Given this list of marker genes IGKV2D-28 (NCBI Gene Id 28883), KIF26B, RIN1, TOR1B (NCBI Gene Id 84822), TOR1A, DNASE2, VPS36, UBB, IGLV2-11, AP4B1, DNM2, KLC1, KIF15, COPS6, STAM, NAA35, KIF20A, TRAPPC13, EPGN, SURF4, GNS, PAFAH1B2, COL3A1, COG7, GOLGA1, TBC1D4, BICD2, HPS1, COPB2, ANKRD28, CALM1, IGLV1-40 (NCBI Gene Id 28825), SYS1, GJB7, RAB13, DENND6B, HSPA8, VAMP2, SNAP91, NAPG, STXBP3, TBC1D7, IGKV3-15, MASP1 (MBL associated serine protease 1), CYTH4, STX5 (NCBI Gene Id 6811), MON1B, SCFD1, EPS15L1 (NCBI Gene Id 58513), MON1A, GRB2, TPD52L1, HGS, BLOC1S4, RHOBTB3, SPTBN1, KIF12, DVL2, TBC1D1, TGOLN2, DAB2, PLA2G4A, TRAPPC10, RAB11A, ARPC3, IGHV3-53 (NCBI Gene Id 28420), TUBA4A, CD55, PPP6R1, DYNC1LI1, IGLV1-51, IGLV7-43, IGLV6-57, VPS37A, IGHV3-13, CAPZA1, ARPC2, MCFD2, KIF1C, IGKV1D-12, IGLC3, BIN1, APOA1, HSPH1, RHOQ, CTTN, MAN1C1, GJA1, TMED9 (NCBI Gene Id 96645), TPD52, IGKV3-11, ACTB, AKT2, SNF8, CHMP6, TRAPPC8, TRAPPC2L, RABEP1, KIF22, TUBA1A, AP1S1, VPS45 (NCBI Gene Id 11312), TUBB8B, WASL, SEC24C, ARF3, RAB3IL1, ITSN2, NAPA, SPTB, RAB41, RACGAP1, SNX18, DENND2B, IGLV3-27, SH3D19, NAA38, IGHV3-7, TUBB8, KIF2B, BET1, RGP1, GJA4, GOSR1, KIF5A, RAB27B, YWHAB, EGF, ARFRP1, HSP90B1, RAB5C, TMED3, KIF2A (kinesin family member 2A), MAN2A2, F8, TRIP11, DCTN5, KIF25, SEC16B, NEDD8, PIP5K1C, COPS3 (COP9 signalosome subunit 3), YIPF6, MAN1A2, KIF5B, GRIA1, RAB1A, BTC, IGKV2-30, IGLV1-47, ARCN1, RAB33A, RAB33B, SLC18A3, STAM2, RALA, WNT5A (Wnt family member 5A), PLIN3, PRKAB2, AP1S3, RAB3IP, AP4S1, IGLV3-25, RAB18, SCGB3A2, ARFGAP2, MADD, UBQLN2, IGHV4-39, KIF3C, GAPVD1, DENND3, CCZ1 (NCBI Gene Id 51622), TRAPPC4, ARF6, VPS37D, IGKV2D-30, MYO5A, YKT6, COPB1, LRP1, BICD1, COPS7A, DNAJC6, STX17, CAPZA2, DENND2D, LDLRAP1, AP2S1, ARFGAP1, SEC31A, VAMP4, SSC5D, ARF5, NAPB, TUBA3C, AP4M1, PRKAG1, RAB9B, IGHA1, PIK3C2A, EXOC5, RALGAPB, PAFAH1B1, GDI1, SEC13, AP3B1, CSNK1D, AP2A1, GOLGA5, SNAPIN, SAA1, DCTN6, CD3G, SNAP29, CYTH3, SLC2A8, COG1 (NCBI Gene Id 9382), GCC1, ANK1, CHMP2A, REPS2, AP1G2, AP3S1, ACTG1, TBC1D25, TUBB6, ARRB2, IGHV4-59, HBEGF, IGLC2, IGHV1-69 (NCBI Gene Id 652126), EXOC8, KIF18B, GRK3 (NCBI Gene Id 157), PAFAH1B3, GABARAPL2, RAB1B, SH3GL3, ACTR10, EXOC4, SEC23IP, F5, DTNBP1, GOSR2, TMED2, SBF1, COG2, PRKAB1, CPD, VPS4A, GGA2, APOB, KIF19, IGKV5-2, CLTB, AP2B1, RAB35, EXOC3, BLOC1S3, ALPP, COPZ2, TRAPPC11, RAB38, GJB6, HIP1, EXOC6, CYTH2, IGKV2D-40, C2CD5, SH3GL1, RIN3, UBA52, GOLGA2, LMAN1L, DENND1B, GORASP1, COPA, FCHO1, RAB43, ARF4, COPS7B, VTA1, SNAP23, IGHV3-33, ANKRD27, DENND1C, IGHA2, CTSC, MAN2A1, GJD4, TJP1, ACTR2, DYNLL2, RAB8B, PACSIN2, SYT1, REPS1, CAPZB, HSP90AA1, BNIP1, SPTBN4, UBC, HYOU1, ACTR1A, TBC1D13, GPS1, TRAPPC2, TBC1D15, RAB9A, COPS2, SGIP1 (NCBI Gene Id 84251), VPS37B, IGKV1-5, CNIH3, ARRB1, CHMP7, TBC1D3, AKT3 (NCBI Gene Id 26068), VAMP7, FOLR1, ULK1, IGKV3-20, COL7A1, RAB12, CAPZA3, STX10 (syntaxin 10), SCARB2, CD59, VPS54, TUBA4B, DENND6A, CD4, COPS5, KIF21B, GJC1, SCARA5, GBF1, TF, RAB27A, TUBB2A, GJD3, IGKV1-12, IGKV1-33 (NCBI Gene Id 28933), NSF, TXNDC5, SH3KBP1, COPZ1, TRAPPC12, IGLV2-14, CFTR, VPS53, MIA3, YWHAH, SEC23A, TBC1D14 (TBC1 domain family member 14), MARCO, GCC2, TACR1, DYNC1I1 (NCBI Gene Id 1780), ACTR3, CCZ1B, STX6, EPN1, CLVS1, AVP, COPS4, AP1B1, KLC2, CD36, CUX1, ARFGAP3, GJA10, TRAPPC3, SH3GL2, LNPEP, MAN1A1 (mannosidase alpha class 1A member 1), CLTC, IGKV1D-33, RABGAP1, CHMP4A, KIF23, TFG (NCBI Gene Id 50989), SYT8, EPS15, IGLV3-1, IGLV1-44, PACSIN3, DNM1, TBC1D17, GOLGA4, RIN2 (Ras and Rab interactor 2), ANK2, IL7R, SFN, GOLIM4, RAB21, CHMP2B, IGKV1-39, HBA1, IGHV3-23, GALNT2, STON1, SPTBN2, ARPC1A, TRIP10, IGF2R, INS, IGHV2-70, VAMP8, AGTR1, TBC1D2, CLINT1, HIP1R (huntingtin interacting protein 1 related), SNX5, RAB14, PUM1, CHMP3, MAP1LC3B, AVPR2, CNIH1, TUBA3E, NECAP1, IGHV3-11 (NCBI Gene Id 28450), RAB10, IGLV2-23, RAB3A, SRC, KIF1A, DYNC1H1, AP1M1, AGPAT3, MYH9, COG6, ALS2, TGFA, GDI2, AP4E1, AP1S2, HPR, SPTAN1, FNBP1, SEC31B, GGA3, SYT2, RAB31, YWHAE, DCTN1, NECAP2, RAB11B, KIF26A, APP, CLTA, VPS52, IGHV4-34, SLC2A4, COL4A1, PREB, KIF3B, AMPH, IGKV1-16, RPS27A, ADRB2, TBC1D10A, DNM3, KIF4B, KIFC1, STX18, IGKV1D-39, ANK3, HPS4, SEC24B, KIF6, YWHAQ, DENND4A, RALGAPA2, OPTN, RAB6B, LMAN2L, GJB5, COPS8, RAB7A, TFRC, GJA5, IGHV1-46, SNX2, GJB1, SNX9, ARFIP2, FCHO2, RAB4A, CD163, UBQLN1, PRKAG2, MYO1C, IGHV3-30, SYT9, ZW10, GJA3, TUBB2B, BLOC1S1, TMED7, AREG, GJB4, SEC24A, SYNJ1, GJA8, BET1L, PPP6R3, USE1, SEC22C, VPS25 (vacuolar protein sorting 25 homolog), KLC4, COG5, EGFR (epidermal growth factor receptor), MVB12A, GGA1, DYNLL1 (NCBI Gene Id 8655), FNBP1L, KIAA0319, TSC2, CENPE, TUBB4A, BLOC1S6, DYNC1LI2, IGLV3-19, CD3D (NCBI Gene Id 915), RINT1, IGKV4-1, CHMP4C, JCHAIN, DENND5A, CLTCL1, GJA9 (gap junction protein alpha 9), KIFC2 (NCBI Gene Id 90990), RAB32 (NCBI Gene Id 10981), DENND2C, ITSN1, COPE (COPI coat complex subunit epsilon), TUBB1, SBF2, EPN2, ASPSCR1, TUBAL3, TBC1D20, IGHV3-48, DENND4C, LMAN1, STON2, MYO6, COPG2, IGLV3-21, CHRM2, RIC1, RAB3GAP1, IGLV2-8, TRAPPC6A, CHMP4B, COG4, EXOC2, SERPINA1, TSG101, CLVS2, ARPC5, SPARC, DENND5B, M6PR, KDELR1, HPX, NBAS, PRKAG3, KDELR3, KIF27, KIF20B, TBC1D8B, PLA2G6, COLEC12, GALNT1, UBAP1, RAB7B, EXOC7, LRP2, AAK1, STAB2, AP1G1, TBC1D16, GABARAP, AP1M2, COPG1, SEC22A, KIF3A, TRAPPC6B, AKT1, EREG, LDLR, COG3, SCARF1, TRAPPC1, DCTN4, RINL, GAK, TMEM115, RAB39A, DYNC1I2, RAB39B, COG8, KIF1B, PRKAA2, RAB36, AP2M1, RAB8A, TSC1, PICALM, RAB6A, AMBP, SYTL1, KIF11, SPTA1, SPTBN5, SCOC, ARF1, COL1A1, COL4A2, AP2A2, RAB30, DENND1A, ARL1, STX4, KIF18A, STX16, PPP6C, MIA2, IGHV2-5, KIF2C (NCBI Gene Id 11004), IGHV1-2, VPS28, GOLGB1, RABGEF1, SEC24D, DCTN3, TUBA1B, TBC1D10B, CHM, KIF21A, KIFAP3, DENND2A, DENND4B, CBL, COLEC11, RAC1, TUBA3D, SEC16A, FTH1, VPS51, KIF16B, LMAN2, STAB1, MSR1, SEC22B (NCBI Gene Id 9554), GJB2, RAB5B, ACBD3, APOE, RABEPK, SAR1B, FZD4, VAMP3, IGKV3D-20 (immunoglobulin kappa variable 3D-20), DCTN2, USP6NL, APOL1, TBC1D24, GRK2, MVB12B, CYTH1, CTSZ, HBA2, EXOC1, HBB, NAA30, SYNJ2, TUBB4B, YWHAZ, CHMP5, GJB3, KIF9, TUBB3, KIF13B, TBC1D10C, VPS4B, USO1, HP, KIF4A, CHML, KDELR2, IGKV1-17, IGKV2-28, GJC2, VPS37C, OCRL, TRAPPC5, SORT1, TUBA1C, ARPC4, KLC3, TUBA8, IGKV1D-16, YWHAG, TMED10, CALR, CNIH2, SCARB1, TRAPPC9, RAB3GAP2, TMF1, ALS2CL, AGFG1, PACSIN1, ALB, COL1A2, GJD2, SYT11, FTL, RAB5A, VTI1A, here is a description of the gene set: Human Gene Set: REACTOME_VESICLE_MEDIATED_TRANSPORT Vesicle-mediated transport studied in species Homo sapiens